Given this list of marker genes GABRP (NCBI Gene Id 2568), GABRB1, GABRD, CHRNB3, GLRA2, HTR3A, GLRA1, GABRB3, GABRA5, GABRB2, GLRB, GLRA3, GABRA2, GABRA6, GABRG2, here is a description of the gene set: Neurotransmitter (GABA) receptor. Human Gene Set: MODULE_215 species: Homo sapiens